Given this list of marker genes ULK1, IFRD1, RGMA, FSTL4, DCC, EPHA7, ULK2, SPART, SPP1, PTPRS, FGF13, BCL11A, here is a description of the gene set: Human Gene Set: GOBP_NEGATIVE_REGULATION_OF_COLLATERAL_SPROUTING Any process that stops, prevents, or reduces the frequency, rate or extent of collateral sprouting. studied in species Homo sapiens